The following is a description of a gene set: Human Gene Set: HP_WEAKNESS_OF_THE_INTRINSIC_HAND_MUSCLES Weakness of the intrinsic hand muscles species: Homo sapiens, and this is the list of marker genes: DOK7, CAV3, RAPSN (NCBI Gene Id 85713), CHRNA1 (cholinergic receptor nicotinic alpha 1 subunit), NEB, AK9 (adenylate kinase 9), MB, STIM1, LRP4, SCN4A, CHRNB1, MPV17, LDB3, CHRNE (NCBI Gene Id 83405), AGRN, VCP, SIGMAR1, HINT1, MUSK, FBXO38, COL13A1, KLHL9, CADM3, DYSF, CHRND